Given this list of marker genes HLA-B, TAP1, HLA-F, TAPBP, HLA-A, TAP2, HLA-C, here is a description of the gene set: Binding to TAP protein, transporter associated with antigen processing protein. TAP protein is a heterodimeric peptide transporter consisting of the subunits TAP1 and TAP2. species: Homo sapiens Human Gene Set: GOMF_TAP_BINDING